The following is a description of a gene set: studied in species Mus musculus Mouse Gene Set: REACTOME_INTRACELLULAR_SIGNALING_BY_SECOND_MESSENGERS Intracellular signaling by second messengers, and this is the list of marker genes: Chd4, Rragc, Esr1, Fgf17, Bdnf, Pdgfra, Chd3, Pip4k2b, Lck, Pip4k2c, Sgk1, Il1rl1, Ppp2r1b, Il1rap, Ppp2cb, Psma1, Rbbp4, Adrm1, Traf6, Otud3, Frk, Uba52, Fgf4, Kl, Tgfa, Erbb3, Fgf1, Akt1, Psmc3, Rictor, Pik3ap1 (NCBI Gene Id 83490, phosphoinositide-3-kinase adaptor protein 1), Egfr, Lamtor2, Ppp2r5d, Klb, Nr4a1 (nuclear receptor subfamily 4, group A, member 1), Psmb4, Psmc6, Prkce, Prr5, Camkk1, Calm3, Fgf9, Pdgfb, Ereg, Ppp2r5b, Adcy6, Grk2, Ier3, Csnk2a2, Fgf3, Psmd6, Ubc, Tsc2, Rnf146, Rptor, Mapk3, Mapk1, Psmd12, Irak4, Ppp2r1a, Rac1, Pik3ca, Adcy4, Icos, Fgf22, Psmd13, Erbb4, Psmd7, Ntf5, Fgf15, Csnk2b (NCBI Gene Id 13001), Psmd8, Erbb2, Frs2, Lamtor1, Grb2, Fgfr3, Pde1c, Stub1, Calm2, Hdac1 (NCBI Gene Id 630524), Them4, Pdgfa, Pml, Psma2, Pip5k1c, Irak1, Fgf6, Psmb1, Vav1, Ptpn11, Mbd3, Prkcg, Myd88, Sall4, Kit, Rps6kb2, Egf, Usp7, Kitl, Mapkap1, Psma7, Pip5k1a, Calm1, Gab1, Mkrn1, Pik3cb, Pde1a, Chuk, Pde1b, Ppp2r5e, Rragb, Ntrk3, Pik3cd, Irs2, Ubb, Fgf8, Psmd2, Rps27a, Rragd, Csnk2a1, Ppp2r5c, Btc, Ppp2r5a, Psmd1, Nrg1, Fgf20 (fibroblast growth factor 20), Tnks2, Cd80, Akt2, Adcy3, Prkcd, Fyn, Epgn, Pik3r2, Mta1, Lamtor5, Pik3r3, Adcy7, Adcy2, Prex2, Psma3, Mdm2, Adcy8, Psmc5, Prkaca, Nedd4, Psmb5, Mta3, Psmd14, Insr, Areg, Foxo3, Pten, Foxo4, Cd86, Pdgfrb, Usp13, Fgf10, Rbbp7, Psma4, Cdkn1a, Phlpp1, Nrg3, Lamtor3, Pik3r5, Rhog, Phlpp2, Fgfr4, Psmb2, Prkacb, Fgf5, Esr2, Fgf23, Fgf2, Ppp2ca, Cd28, Psmc2, Gatad2b, Psmb6, Fgf16, Mta2, Pik3r1, Il33, Strn, Psmc4, Adcy5, Pik3cg, Pdpk1, Prkar1b, Psma5, Psmb3, Rac2, Fgfr1, Rheb, Psmd3, Psmb7, Rraga, Foxo6, Maf1, Met, Src, Akt3, Mtor, Trim27 (tripartite motif-containing 27), Gatad2a, Pip5k1b, Fgf7, Adcy1, Psmc1 (NCBI Gene Id 19179), Slc38a9, Prkar1a, Fgf18, Creb1, Trib3, Cdkn1b, Ntrk2, Ntf3, Ins1, Flt3l, Cd19, Psma6, Mlst8, Trat1, Adcy9, Hbegf, Casp9, Psmd11, Pip4k2a, Uba52rt, Lamtor4, Wwp2, Pik3r6, Akt1s1, Tnks, Camkk2, Foxo1, Hgf, Xiap